The following is a description of a gene set: from publication Yevshin I, Sharipov R, Kolmykov S, Kondrakhin Y, Kolpakov F (PMID 30445619) studied in species Mus musculus Genes containing one or more binding sites for (Ddx5) in their promoter regions (TSS -1000,+100 bp) as identified by GTRD version 20.06 ChIP-seq harmonization. Mouse Gene Set: DDX5_TARGET_GENES, and this is the list of marker genes: Bax, Mcoln1, Mfsd1, Gns, Ubxn1, Ube2q1, Nsmce2, Mtdh, mt-Nd6, Gm8066, Ndel1, Trpm7, 4632404H12Rik (RIKEN cDNA 4632404H12 gene), Gm8357, mt-Cytb, Sppl3, Mthfr (methylenetetrahydrofolate reductase), Ankrd12, Amdhd2, Clcn6, Dyrk1b, mt-Tm, Atxn3, Washc2, Dvl2, Lamp1, Atp6v0b, Fam118b, Pip4p1, Rpusd4, Hoxa7, Get4 (NCBI Gene Id 67604), Lamtor1, Washc5, Zfp507, Ilf3, Zmym6, mt-Nd2 (mitochondrially encoded NADH dehydrogenase 2), Rmnd1, Armt1, mt-Ti, Hexa, mt-Te, Vps26a, Zbtb40, Pias2